The following is a description of a gene set: Mouse Gene Set: MIR_3475_5P_MIR_96_3P studied in species Mus musculus from publication Chen Y, Wang X (PMID 31504780) Genes predicted to be targets of miRBase v22 microRNA mmu_miR_3475_5p, mmu_miR_96_3p in miRDB v6.0 with MirTarget v4 prediction scores > 80 (high confidence targets)., and this is the list of marker genes: Ptchd4, Cyba, Dpy30, Alg5, Rapgef2, Nipa1, Rorb, Ptgs2, Btg1, Mrm2, Tes, Nox4, Usp9x, Asph, Rprd1a, Macir, Tmem41a, Cops2, Nfyb, Ahnak, Gpm6a, Prdm6, Tmem33, Pgrmc1, Tmod2, Krit1, Arl6, Kpna3, Nexmif (NCBI Gene Id 97590), Cct8, Flg2, Eif4a2, Potefam3a, Otol1, Potefam3b, Lrrc49, Ceacam12, Pcdhb14, Nampt, Inava, Tctn3, Mylk3, Lpp, Hnrnpr, Zfp758, Kdelr1, Ptpn9, Fut9, Vps37b, Brwd1, Gpr82, Zfp277, Lamc1, Ppargc1a, Sf3b1 (NCBI Gene Id 98194), Epyc, Cdk1, Neu4, Dcaf8l, Arpp19, Fam185a, Mbnl2, Hecw1, Gimap8, Bptf